The following is a description of a gene set: Human Gene Set: chr1p33 species: Homo sapiens, and this is the list of marker genes: NENFP1, CYP4A11, TMEM275, CYP4Z1, MKNK1, SPATA6, STIL, CYP4A43P, TUBAP8, MTND1P34, FAAH, AGBL4-AS1, CYP4X1, CMPK1, UQCRH, LINC01738, FOXD2, PPP1R8P1, PDZK1IP1, RNU4-61P, TRABD2B, FOXE3, LINC02794 (long intergenic non-protein coding RNA 2794), CYP4Z2P, CYP4A22-AS1, CYP4A22, TEX38, MTND2P29, SKINT1L, EFCAB14, LRRC41, MOB3C, ELAVL4-AS1, RPL21P24, AGBL4-IT1, CYP4A26P, FAAHP1, LINC00853, TAL1, RNU6-723P, NSUN4, LINC01389, AGBL4, BEND5, SLC5A9, CYP4A27P, EFCAB14-AS1, RPL21P25, LINC01398, ZNF859P, ATP6V0E1P4, CYP4B1, DMBX1, MKNK1-AS1, ELAVL4, TUBAP9, CYP46A4P, ATPAF1, FOXD2-AS1, KNCN, CYP4A44P